Given this list of marker genes Niban1, Nupr1, Wnt5a, Adh7, Trip12, Plscr4, Sh3bp5, Taf9b, here is a description of the gene set: The reciprocal chromosomal translocation t(4;11) is correlated with infant, childhood, adult and therapy-related high-risk acute leukemia. Here, we investigated the biological effects of MLL.AF4, AF4.MLL or the combination of both reciprocal fusion proteins in a conditional in vitro cell culture model system. Several parameters like cell growth, cell cycling capacity, apoptotic behavior and growth transformation were investigated under physiological and stress conditions. Co-transfected cells displayed the highest resistance against apoptotic triggers, cell cycling capacity and loss-of-contact inhibition. These analyses were complemented by gene expression profiling experiments and specific gene signatures were established for each of the three cell lines. Interestingly, co-transfected cells strongly upregulate the homeobox gene Nanog. In combination with Oct4, the Nanog homeoprotein is steering maintenance of pluripotency and self-renewal in embryonic stem cells. Transcription of Nanog and other stem cell factors, like Oct4 and Bmi1, was verified in biopsy material of t(4;11) patient cells which express both reciprocal t(4;11) fusion genes. In conclusion, the presence of both reciprocal MLL fusion proteins confers biological properties known from t(4;11) leukemia, suggesting that each of the two fusion proteins contribute specific properties and, in combination, also synergistic effects to the leukemic phenotype. studied in species Mus musculus Mouse Gene Set: GAUSSMANN_MLL_AF4_FUSION_TARGETS_B_DN Down-regulated genes from the set B (Fig. 5a): specific signature shared by cells expressing either AF4-MLL or MLL-AF4 fusion proteins. from publication Gaussmann A, Wenger T, Eberle I, Bursen A, Bracharz S, Herr I, Dingermann T, Marschalek R (PMID 17130830)